The following is a description of a gene set: Mouse Gene Set: GOBP_REGULATION_OF_MODIFICATION_OF_POSTSYNAPTIC_STRUCTURE studied in species Mus musculus Any process that modulates the frequency, rate or extent of modification of postsynaptic structure., and this is the list of marker genes: Chmp2b, Cap2, Egln1, Nf1, Tiam1, Camkv, Baiap2, Amot, Itsn1, Dip2a, Cttnbp2, Rapgef2, Cyfip1 (NCBI Gene Id 29878), Prmt8, Ptk2, Marcks, Myo5b, Rhoa, Kalrn, Gsk3b, Pdxp, Cdc42, Strn4, Rhob, Myh10